Given this list of marker genes Dlg2, Lrrc4, Csmd2, Prickle1, Grid2, Ptprd, Crk, Ntng2, Cnksr2, Nlgn1, Nptx1, Il1rap, Prickle2, Zdhhc12, Lrrtm2, C1ql3, Nlgn2, Zmynd8, Nrxn2, Dgkz, Dlg1, Crkl, Tmem108, Lrfn4, Slitrk3, Sipa1l1, Nrxn1, Cbln1, Cdh2, Sptbn2, Shank1, Caskin1, Cntnap2, Insyn1, Dbn1, Ptprs, Cntnap1, Cript (NCBI Gene Id 80506, cysteine-rich PDZ-binding protein), Adgrl3, Abi3bp, Abl1, Ntrk3, Wnt5a, Fgfr1, Lrrc4b, Cadm1, Nlgn3, Dock7, Cit, Lats1, Abi3, Rapsn, Ophn1, Ptk2b, Pten, Shank3, Lrfn1, Gap43, Mpp2, Syngap1, Reln, Itgb1, Nptxr, Lrrtm1, Slc30a1, Cfl1, Nrxn3, Arf6, Itgb3, Hspa8, Myo9a, Arhgef9, C1ql2, here is a description of the gene set: A process that results in the assembly, arrangement of constituent parts, or disassembly of a postsynaptic specialization, a structure that lies adjacent to the cytoplasmic face of the postsynaptic membrane. Mouse Gene Set: GOBP_POSTSYNAPTIC_SPECIALIZATION_ORGANIZATION studied in species Mus musculus